Given this list of marker genes Aqp1, Rhbg, Slc12a5, Slc12a6, Rhcg, Slc12a2, Aqp8, Rhag (Rhesus blood group-associated A glycoprotein), Aqp6, Rhd, Hcn2 (hyperpolarization-activated, cyclic nucleotide-gated K+ 2), here is a description of the gene set: Mouse Gene Set: GOBP_AMMONIUM_TRANSMEMBRANE_TRANSPORT species: Mus musculus The process in which ammonium is transported across a membrane. Ammonium is the cation NH4+.